The following is a description of a gene set: species: Mus musculus Mouse Gene Set: GOBP_VASCULAR_PROCESS_IN_CIRCULATORY_SYSTEM A circulatory process that occurs at the level of the vasculature., and this is the list of marker genes: Kcna5, Abcg2, Grip2, Cxcr2, Kcnma1, Itga4, C2cd4a, Egfr, Uts2b, Plekha7, Slc5a6, P2rx4, Itgb1, Tbxas1, Arhgap35, Atp2b1, Icam1, Abcc1, Nppb, Adcyap1, Avpr2, Fgb, Smtnl1, Calca, Sh3gl2, Ptk2, Ptgs2, Npr3, Gch1, Capn1, Drd5, Dbh, Cldn5 (NCBI Gene Id 21920), Tjp2, Svep1 (NCBI Gene Id 80647), Agtr1b, Per2, Bbs2, Cbs, Abl1, Adra1d, Ager, Apln, Mkks, Faah, Cx3cl1, Adcy6, Ctnnbip1, Gclc (glutamate-cysteine ligase, catalytic subunit), Slc2a1, G6pdx, Abcb1a, Apoe, Ptgs1, Ext2, Ocln, Slc22a1, Edn3, Fgfbp3, Adora2a, Abcb1b, Akt1, Sod3, Vegfa, Uts2, P2ry2, Grk2, Nts, Gper1 (G protein-coupled estrogen receptor 1), Kdr, Oxtr, Abcg3, Abcc9, Hmgcr (NCBI Gene Id 218474), Cftr, Cps1, Slc1a5, Alox5, Chrm3, Adra1a, Angpt1, Scpep1, Adra2a, Ednrb, Mrgprd, Shc1 (NCBI Gene Id 20416), Fermt2, Itga1, Adrb2, Nos1, Smad6, Ptprm, P2ry1, Tacr1, Uts2r (NCBI Gene Id 217369), Tgfbr3, Kcnj8, F2r, Bmpr2, Edn1, Cyp2j5, Agtr2, Rhoa, Bdkrb2, Adm, Pde2a, Nr3c1, Mgll, Dock4, Ptprj, Wdr35, Bloc1s6, Htr1d, Foxc2, Asic2, Ddah1, Amot, Itgb1bp1, Atg5, Zdhhc21, Map2k1, Pde5a (NCBI Gene Id 242202), Cacna1c, Mtnr1b, Rbfox2, Gpx1, Sirt1, Stub1, Adra1b, Hif1a, Htr2a, Casr, Rap1gds1, Htr2c, Mmp2, Acta2, Adrb3, Gja5, Slc27a4, Tnf (tumor necrosis factor), Ceacam1, F2rl1, Hrh1, Kng2, Arhgap42, Avpr1b, Avp, Snta1, Avpr1a, Plod3, Ptger3, Htr1a, Klk1b1, Itga9, Ucn, Crp, Dusp5, Bcr, Cdh5, Il18, Irag1, Mylk3, Edn2, Kat2b, Ins2, Abr, Prkg1, Plec, Slc16a2, C2cd4b, Adra2b, Ece1, Lep, Vstm4, Tgfb1, Slc27a1 (NCBI Gene Id 26457), Ins1, Lrp1, Pla2g6, Tacr2, Tjp1, Flvcr2, Adrb1, Atp1a2, Ext1, Drd1, Nppc, Slit2, Tbxa2r, Gucy1a1, Trpm4, Agt, Slc6a4, Slc22a2, Dock5, Serpinf2, Nos3, Cd36, Bmp6, Tjp3, Add3, Htr7, Htr1b, Nppa, Ppard, Zeb2, Rock1, Npr1, Esr2, Cd38, Scnn1b, Abcc8, Pdgfb, Ifnb1, Pde3a, Kcnmb1, P2rx1, Htr2b, Comp, Npy1r, Fgg, Fabp5, Rgs2, Kng1, Smpd3, Rock2, Gpr4, Ccl4, Ptp4a3, Fga, Ramp2 (receptor (calcitonin) activity modifying protein 2), Ednra, Adora2b, Akap12, Manf, Ace, Abcc2, Cysltr1, Mfsd2a, Sod2, Agtr1a, Chga, Cacna1g, Gclm, Hrh2, Mas1, Klf2, Gja1, Slc5a1, Ahr, Trpv4, Sod1, Adra2c, Adora1, Foxc1, Slc8a1, Plvap, Cav1, Slc22a5